Given this list of marker genes C19orf12, BFSP2, KLHL25 (NCBI Gene Id 64410), DCTN5, RDH12, FUNDC1, IFT70B (NCBI Gene Id 150737), HELZ, CYP4F3, CKLF, OTUD5, PLAAT3, SDHA, ACADSB, CNRIP1, CD81, PRKAG1, CENPU, NUDT16, EHHADH, SIDT1 (NCBI Gene Id 54847), INVS, HIP1R, SIGIRR, ANKMY2, MPND, CDS2, CCDC181, SH3PXD2A, GPX4, CYTH4, ZBTB24, PSMB10, SLC28A2, GCFC2, ARHGAP6, PPP1R21, DCLK2 (doublecortin like kinase 2), HAUS5, NID1, PRKCB, AURKB, DNAJB4, CPNE6, FBH1, ECH1, PIK3CD, RCHY1 (NCBI Gene Id 29027), MGAT4A, PDE4B, DPYSL2, INSL6, FANCA, TEDC1, TMED3, SMIM19, PNKP, HCLS1, UBE2D1, BTG2, CASP7, TAP2, MAPK11, FAM3A, BCL9L, MFSD14B, RMDN1, OAS1, NFYA, PIK3R1, PPP3CC (NCBI Gene Id 5533), SPNS3, BCKDHB, TBXA2R, TOB1, S1PR1, PPP1R12A, ACP1, HERC2, ACTG1, APOBEC3B, RFLNB, MYO18A, PREX1, NARF, CYP4V2, DHRS7, FAM107B, PRIM2, DHX57, BIRC3, OGA, INPP1, CISD3, COPG2, RASSF3, DCAF17, IFT27, TDRD7, STING1, PRKACA, CD1D, BTLA, MTA3, AFF3, NEDD4, SRGAP2, SLC25A12, GMNN, CCPG1, ZMYM3, TMEM64, SELENOO, TNFRSF13B, MAN2B1, DLG3, CSRP2, PPCDC, AFG1L, FERMT3, PRR14, UNC13D, TREML2 (NCBI Gene Id 79865), PARD6A, PTPN6, SPICE1, RALGPS2, POU2F2 (NCBI Gene Id 5452), HPS3, PHYHD1, PXK, SGPP1, UGP2, CSAD, HIBADH, SUOX, MARF1, GBP2, EMID1, TUT7, GIMAP4, C16orf54, SIKE1, TMEM9, IKBIP, ASB1, ABCA7, ITGAL, ZNF236, CFAP68, GCNT1, GLG1, SDHAF2, SQOR, RAB39A (NCBI Gene Id 54734), ANP32A, ATG101, TMEM268, TNS3, TSNAXIP1, GDAP2, SELP, ARID4A, IAH1, RNF145, TBC1D9B, FES, NRDC, OTUB2, CTBS, FAM117A, RFC5, ZRANB3, RECQL5, PDCD4, NOD1, FCSK, CDC42SE2, RGS18, SCNM1, SPNS2, CIB1, TEX9, NAT1, SMIM20, BBS9, SIK1, HIGD2A, KDM7A, DEXI, NOXRED1, ITM2B, LCA5, DOK3, LMAN2L, CCNG1, ACTR8, CORO1B, DENND1C, ATP11C, here is a description of the gene set: species: Homo sapiens from publication Felker P, Seré K, Lin Q, Becker C, Hristov M, Hieronymus T, Zenke M (PMID 20881193) Dendritic cells (DCs) in lymphoid tissue comprise conventional DCs (cDCs) and plasmacytoid DCs (pDCs) that develop from common DC progenitors (CDPs). CDPs are Flt3+c-kitintM-CSFR+ and reside in bone marrow. Here we describe a two-step culture system that recapitulates DC development from c-kithiFlt3-/lo multipotent progenitors (MPPs) into CDPs and further into cDC and pDC subsets. MPPs and CDPs are amplified in vitro with Flt3 ligand, stem cell factor, hyper-IL-6 and insulin- like growth factor-1. The four-factor cocktail readily induces self-renewal of MPPs and their progression into CDPs and has no self-renewal activity on CDPs. The amplified CDPs respond to all known DC poietins and generate all lymphoid tissue DCs in vivo and in vitro. Additionally, in vitro CDPs recapitulate the cell surface marker and gene expression profile of in vivo CDPs and possess a DC-primed transcription profile. Transforming growth factor-β1 (TGF-β1) impacts on CDPs and directs their differentiation towards cDCs. Genome-wide gene expression profiling of TGF-β1-induced genes identified transcription factors, such as interferon regulatory factor-4 (IRF-4) and RelB, that are implicated as instructive factors for cDC subset specification. TGF-β1 also induced the transcription factor inhibitor of differentiation/DNA binding 2 (Id2) that suppresses pDC development. Thus, TGF-β1 directs CDP differentiation into cDC by inducing both cDC instructive factors and pDC inhibitory factors. Genes down-regulated in cultured common dendritic cell progenitors: untreated versus TGFB1 for 4h. Human Gene Set: GSE22432_UNTREATED_VS_TGFB1_TREATED_COMMON_DC_PROGENITOR_DN